Given this list of marker genes TWF1, MSX2, KPNA5, CA5B, INHBA, MAFF, ZNF16, IDI2-AS1, CASQ2, HFE, GPM6A, ZNF8, FILIP1L, ARHGEF4, IL1B, OR2H1, RETREG1, LAGE3P1, DKK2, PCDHGA10, ZBBX, LY6G6E, CYP2C18, CHD9, SLC11A2, PRKAB2, PHOX2B, PGM3, NAP1L3, MIA2, LINC01949, SH3BP2, B4GALT6, MAP4K4, KRT76, ITPR1, RRN3P1, ADAM12, TPX2, TMPRSS11E, PTPN22, SSX2IP, THOC2, IDH3A, GAD2, MTUS1, MATN1, HTR1E, GLI2, SMAD4 (SMAD family member 4), ANKRD6, RAD51, SCLY, IL21R, CDH19, GUCY2C, COL15A1, NKX3-1, CHRNA9, ATF3, MNAT1, PTPRM, ERBB4, DAB2, POLR3B, CLDN18, SEC22B, CLIC5, ANK3, CXCL3, PTGS2, IRF5, ABRAXAS2, ZBTB1, PRKG2, ADCY3, ZNF835, CEP68, B4GALT5, POU5F1P4, ATP10A, NR4A2, SERPINB9, HACD1, MOBP, ADAMTS3, SCN2A, ADNP2, MMP24, IL1A, PMEPA1, SPON1, ULK4, PPFIA3, CACNA1A, HILPDA, ZNF365, EGR1, SUV39H2, GOLPH3L, SLC28A1, POLQ, MRPS14, LAMC1, LDAH, FOXN3-AS2, TRAF1, GCLC, ADAMTS20, MRPL15, G0S2, SFRP1, PSG3, LEPR, TPRA1, ID2, RPH3A, BAG2, AP4E1, ITPK1, SLC28A3, TRIM44, TSC22D1, LIMS1, MYOZ2, PACSIN3, LRRC20, PLPP3, SLC25A12, DNASE2, BBS10, AKR1D1, IFNA7, MEX3D, NUAK1, C2, PLCB3, EOLA2-DT, ETHE1, KLK11, EDDM3B, MAPK8, PIMREG (PICALM interacting mitotic regulator), ATF5, FRK, TMEM144, SLC2A1 (NCBI Gene Id 6513), DCLK1, ARSJ, GGH, SH2D1A, CYLC2, NDN, CLEC5A, CWH43, S100G, GRIA3, IREB2, CDH4, DDX56, SOX15 (SRY-box transcription factor 15), TGM2, CDKAL1, ADAMDEC1, FUT3, CELSR2, EGR3, XBP1, FDPS, TMED10, DNAH2, MBNL3, MASP1, CUL5, KLK13, ERC2, CXCL1, KRTAP9-9, IL12A, NF1, AFF4, SLC33A1, COL4A1, AQP4, EBI3, DDX18, DDIT4, KDELR1, SIKE1, ZC3H13, PLA1A, CYP2U1, PCLO, SLC6A9, OPCML, ENPP1, here is a description of the gene set: Genes up-regulated in cytotoxic T cells: control versus treated with Akt inhibitor VIII. In cytotoxic T cells (CTL), Protein Kinase B /Akt is activated by the T cell antigen receptor (TCR) and the cytokine Interleukin 2 (IL2), in part by phosophorylation of Akt by Phospholipid dependent kinase 1 (PDK1). The role of PDK1 and Akt in CTL has however not been fully defined. In order to explore the relative roles of these kinases in CTL we used microarrays to profile the gene expression of control and PDK1 null CTL. In separate experiments we compared the gene expression profiles of control and Akt inhibitor treated CTL. species: Homo sapiens Human Gene Set: GSE26290_CTRL_VS_AKT_INHIBITOR_TREATED_ANTI_CD3_AND_IL2_STIM_CD8_TCELL_UP from publication Macintyre AN, Finlay D, Preston G, Sinclair LV, Waugh CM, Tamas P, Feijoo C, Okkenhaug K, Cantrell DA (PMID 21295499)